Given this list of marker genes Klhl24, Mef2c, Ssh2, Pnisr, Spns3 (SPNS lysolipid transporter 3, sphingosine-1-phosphate (putative)), H2-DMb1, Rgs1, Cd209a, Gpi1, Clec12a, Kctd12, Dap, Eef1d, Zeb2, Uba52, Ypel3, Ramp1, here is a description of the gene set: Cytokines mediate cell-cell communication in the immune system and represent important therapeutic targets. A myriad of studies have highlighted their central role in immune function, yet we lack a global view of the cellular responses of each immune cell type to each cytokine. To address this gap, the authors created the Immune Dictionary, a compendium of single-cell transcriptomic profiles of more than 17 immune cell types in response to each of 86 cytokines (>1,400 cytokine-cell type combinations) in mouse lymph nodes in vivo. A cytokine-centric view of the dictionary revealed that most cytokines induce highly cell-type-specific responses. For example, the inflammatory cytokine interleukin-1β induces distinct gene programmes in almost every cell type. A cell-type-centric view of the dictionary identified more than 66 cytokine-driven cellular polarization states across immune cell types, including previously uncharacterized states such as an interleukin-18-induced polyfunctional natural killer cell state. studied in species Mus musculus Mouse Gene Set: CUI_PDC_IFNK_RESPONSE_DN Genes negatively differentially expressed in cell type: pDC (plasmacytoid dendritic cell) upon treatment with cytokine: IFN-κ in mouse lymph nodes in vivo. from publication Cui A, Huang T, Li S, Ma A, Pérez JL, Sander C, Keskin DB, Wu CJ, Fraenkel E, Hacohen N (PMID 38057668)